The following is a description of a gene set: species: Homo sapiens Impaired renal concentrating ability A defect in the ability to concentrate the urine. Human Gene Set: HP_IMPAIRED_RENAL_CONCENTRATING_ABILITY, and this is the list of marker genes: CLCNKB, SEC61A1, CLCNKA, BSND, CEP290, NPHP1 (nephrocystin 1), FAM20A